Given this list of marker genes PEX5, KCNN3, RAG1, GABRD, LAS1L, CHD4, MAP3K20, ANAPC1, BGN, HSPG2, CTCF, CDC45, ZSWIM6, KIF5C (kinesin family member 5C), VAC14, PIGN, ZMIZ1, CDT1, NEK1, PRKCZ, VPS35L, COL11A1, CHST11, SPART, ALOX12B, PTHLH, HDAC4, ITPR1, PIGL, PAPSS2, IDUA, LIFR, FBN1, TBX4, USP7, OCA2, TPR, SATB2, B3GLCT, SMC3, COG1, XYLT1, SMOC1, HERC2, HDAC8, NTNG1, TBCE, CAMK2A, SLC35C1 (solute carrier family 35 member C1), ALPL, COMP, HEATR3, PIGG, FAT4, SON (NCBI Gene Id 84155), MAP3K7, SMARCA4, SLC10A7, CUL4B (NCBI Gene Id 8450), TRIP11, RMRP, UBE2A (NCBI Gene Id 7319), OFD1, GJB2, LIG4, KMT2A, FIG4, GJA1, HBA2, SALL1, MAPK8IP3, FGD1, ORC4, C12orf57, DLK1, IFT122, HNRNPR, WNT10B, NDN, IL2RG, STXBP1, ROBO1, ADA (adenosine deaminase), ADNP, CDH11, B3GALT6, PWAR1, MYCN, NIPBL, WDR81, LRP4 (NCBI Gene Id 4038), PPIB, EXOC6B, SATB1, PDPN, CHD7, CCBE1, RAD21, PHF6, RTL1, DOCK6, TAF6, NGLY1, KCNJ8, TRPV6, GNAS, WASF1, SMAD4, HEPHL1, NOTCH2, RSPO2, MTHFS, CCDC28B, WDR19, CASZ1, GPC4, CANT1, IFNGR1, RERE, CPLX1, CDKL5, LMX1B, DLX5, TRPV4, ASAH1, HOXD13, NOG, CTBP1, COX4I1, RAG2, KDM5C, CCN2, TRRAP, LETM1, SLC26A2 (NCBI Gene Id 1836), FBXL4, DDRGK1 (NCBI Gene Id 65992), NANS, CPLANE1, TRAF3IP1, MTX2, FLNB, NPAP1 (nuclear pore associated protein 1), DYNC2I2, LUZP1, DACT1, RECQL4, MECP2, PRG4, LZTFL1, RAB34, DCHS1, FZD2, PRMT7, CHST3, CHSY1, TBX5, MMP9, SALL4, PHYH, EXT1, HOXA13, FBXO11, EP300, HYLS1, SLC31A1, SIM1, EIF4A3, AGPS, MIA3, INPPL1, AFF4, ALOXE3, IGF1R, AFF3, RAB23, RIPK4, AIFM1, WDR26, SPEN, SIL1, CENPE, CRELD1, HUWE1, PIGV, TCF4, DYRK1A, VPS13B, GPX4, KAT6A, ZMYM2, ALG12, CDC42BPB, ARL6, PTH1R, CERT1 (ceramide transporter 1), ERI1, TWIST1 (NCBI Gene Id 7967), GRIP1, TBX3, CHUK, LONP1, MASP1, ATP6V1B2, KNSTRN, MKRN3, SHH (NCBI Gene Id 6469), GHR, TBX15 (NCBI Gene Id 6913), KCNJ2, PRDM16, IL7R, H4C3, SF3B4, MATN3, UBE4B, SNRPN, TBL1XR1, BMP2, INTU, PIK3CD, KCNAB2, TAPT1, BHLHA9, PIGF, IHH, KIAA0753, SLC39A13, ATP7A, PPM1D, NOTCH1, AMER1, BBS1, GPC3, CFAP410, SNORD115-1, ATR, MBD5, HDAC6, FGFR1, RAB33B, NSD2, IFT52, MET, WNT7A, POC1A (NCBI Gene Id 25886), GMNN, MMP23B, DCLRE1C, TRPS1, ARID1B, MSL3, CEP120, TGDS, MEG3, HINT1 (histidine triad nucleotide binding protein 1), SVBP, FLNA, DLL4, COL9A1, ROR2, PIK3C2A, USP9X, GPC6, DHCR7, ASXL1 (ASXL transcriptional regulator 1), SUCLG1, SLC35D1, GNPNAT1, ESCO2, PDE4D, PRKAR1A, DYNC2LI1, GJB6, PITX1, UBAP2L, LTBP3, AHDC1, ALMS1, DYM, SERPINH1, CHRNG, BPNT2, EBF3, ASCC3, PWRN1, POLR3A, EZH2, AMMECR1, SNORD116-1, POP1, KDM4B, ZNF407, IFT80, TUBB3, SLC35A2, RBM8A, TMEM67, DYNC1H1, LAMA5, ARSL, RNF2, CCN6 (cellular communication network factor 6), FKBP10, COL2A1, GALNT2, IFT140, PUF60, HBA1, MAGEL2, LMBR1, PDGFRB, NSUN2, DNMT3A, IQCE, CTC1, PIGS, ADAMTS2, TONSL, ADAMTSL2, CCDC47, LBR, FMR1, CDC6, GLI3, WLS, TNNT3, CHD6, GDF5, ACVR1, LMNA, FAM50A, FGFR3, KCNH1, IFT172, DYNC2H1, ZFX, ABCC9, GNA11, DYNC2I1, SIN3A, SPECC1L, MMP13, WDR35, HTT (NCBI Gene Id 3064), EXT2, CAMK2G, NELFA, RAB3GAP2, SMARCA2, TELO2, SMC1A, RBPJ, MGP, COL3A1, FN1, EOGT, MBTPS1, ARHGAP31 (NCBI Gene Id 57514), PORCN, DONSON, TP63, TBC1D24, TRAPPC2, BMPR1B, TCTN3 (NCBI Gene Id 26123), PEX7, KCNJ5 (NCBI Gene Id 3762), UBR7, COG4, PRKG2, FLI1, ERF, APC, RNU4ATAC, NSDHL, ARL6IP6, WNT3, FGFRL1, TBX22, SRY, KAT6B, TNFRSF11A, RSPRY1, CTSK, FGFR2, SHOX, TTC21B, GABBR2, ORC6, BRD4, SOX9, NPR2, RUNX2 (NCBI Gene Id 860), ORC1, SKI, here is a description of the gene set: Absence (due to failure to form) or underdevelopment of the bones of the lower limbs. studied in species Homo sapiens Aplasia/hypoplasia involving bones of the lower limbs Human Gene Set: HP_APLASIA_HYPOPLASIA_INVOLVING_BONES_OF_THE_LOWER_LIMBS